Given this list of marker genes SLC40A1, RAB21, EPHA5, MIR326, COPS5, MIR766, CORO1A (coronin 1A), HCRT, MIR1-1, PTGDR, SYTL3, ERC2, JAK2, MIR199B, BEST1, KCND3, LTBP4, DLG1, RAB1A, SNAP47, ARF6, CPLX4, EXOC3L2, FOXL2, RAP1BL, CHRNA6, ABAT, AP1B1, WASHC1, ARHGAP44 (Rho GTPase activating protein 44), ADAM9, RAB10, F2, C1QTNF12, ITPR1, MYH9, VPS11, TBX3, RHBDF1, TVP23A, RBM4, CALM2, SLC8A3, DAB2, GCG, RPH3AL, STX11, MYO1G, DOC2B, SMCR8, ARFIP1, SCAMP1, IL11, RFX3, MECP2, PDZD11, SNAPIN, GRM7, FBXO45, ABCC8, LAT2, CYB5R4, HTR2A, SERP1, ADAM17, KDM5B, RIMS4, HRH3, MICAL3, ARL4D, CRHBP (NCBI Gene Id 1393), HYAL3, ECRG4, NOTCH1, TMEM132A, NLGN1, LAMP1, ADRA2B, TAC1, FFAR2, SVBP, GOLPH3L, RAB15, MPC2, ILDR1, SIRT4, KCNQ3, LRRC8A, SURF4, CREB3L1, TACR1, CD160, AGT, PHPT1, ACHE, CTAGE9, MYH10, ALOX5 (NCBI Gene Id 240), HPS6, KLRF2, PRKCG, SV2C, DNAJC1, PDIA4, TRARG1, DNAJC5, KCNMB4 (NCBI Gene Id 27345), NCKAP1L, PRKN, OSBPL2, ABCC4, SYN3, OR51E2, SNX19, PFKFB2, SLC12A2, SLC16A2, RAC1, MAFA, SCAMP5, BRSK1, KCNN4, TMEM167B, NRXN1, PPFIA2, CAPN10, RIMS1, CHMP3, SEC24A, RAB11FIP3, SEPTIN1, SAR1B, CLSTN3, PPFIA3 (NCBI Gene Id 8541), UNC13B, OSBP, VAMP8, MIR873, SUCNR1, ADORA1 (NCBI Gene Id 134), VPS18, NR0B2, TMEM163, STX1A, TLR4, MIR30C1 (microRNA 30c-1), CHD7, SELENOT, GDNF, HFE, FBXL20, PRSS12, INHBB, PPARD, IDH2, RAB11FIP2, SIRT3, ABCC2, SYBU, PLA2G6, RAB40AL, HAP1, ATP9A, RAB37, MIR21, BLOC1S3, STXBP5, PIK3CD, TSPAN9, AP1G1, ATP1A2, LRRK2, HIF1A, IL12B (NCBI Gene Id 7907), RALBP1, MIR19B1, WASH3P (WASP family homolog 3, pseudogene), PDX1, PFKL, DPH3, NNAT, MEF2C, ARFGEF2, STX19, HNF1B, GLUD1, CACNB4, EDN1, IRS1, DNM1L, RAPGEF4, TRH, SEPTIN4, BTK, FZD4, ERP29, C1QTNF1, NR1H2, SCG5, FAM3A, FGF10, COMP, GPER1, GNAI2, TMEM79, RAB26, P2RX1, SOX11, TCIRG1, ASIC1, KCNQ1, WASH6P, RAB25, RAF1, ABCA12, SEPTIN5, REST, C2CD2L, PLA2G4A, CHRNA3, GPLD1 (NCBI Gene Id 2822), SYP, C1QTNF3, FXYD6P3, KCNIP2, TNFRSF1A, ABCG2, MYOF, CAMK2G, ABCC5, FXYD3, PRICKLE1, ATP1A1, RIC1, MIA3, CASK, PRRT2, STEAP2, CTAGE15, JAGN1, MRGPRX2 (NCBI Gene Id 117194), AACS (acetoacetyl-CoA synthetase), PTGES, CAVIN1, FXYD7, MICU3, PDCD6IP, ABCA3, ATP1B3, NPFF, KCNK16, EFR3A, SYNGR2, GIPC1, CCL5, SNX4, GNPTAB, SELENOM, GHRL, SYT4, LRP5 (LDL receptor related protein 5), WNK4, SLC9A1, DYSF (dysferlin), SNF8, RAB8B, KCNJ11, ATP13A2, RAB11A (RAB11A, member RAS oncogene family), SLC35G1, WDR41, APBB3, SLC8B1, RAB12, RAB3D, BCR, KLF7, SYNGR3, SYT9, FKBP1B, EXOC6, TRPV6, LGALS9, PIP5K1C, FXYD2, SLC6A4, SMPD3, LEP, ANXA2, RAB33B, AP2B1, OXT, HAMP, ADORA2B, GRM4, PRKD1, KCNK2, F2RL2, FRMD4A, FOXO1, SEL1L, KCNA5, PPY, FGF7, GATA2, EXPH5, MIA2, M6PR, COMT, RAP1GDS1, UBE2Q1, UCN3, FOXA2, NOS2, LYN, SLC38A2, CHRNB4, FFAR4, MIR29B1, UNC13D, ADTRP, NRXN2, HLA-DRB1, KCNK9, SYT3, SYNGR1, ITGAM, SLC47A2, MIR93, SIRT6, RETN, SRCIN1, P3H1, RIMS2, SLC9B2, CTAGE8, ANO1, SYN2, STXBP1, TVP23C, CBLN1, MYO19, TANGO2, CD177, RAB3GAP1, SPP1, TREM2, APBB1, NAPA, SIDT2, SYT10, KCNE5, FMR1, STXBP6, SLC16A1, AVP, CLOCK, MIR19A, RPH3A, INHA, GPR68, APLN, NKX6-1, SYT15, RAC2, FUT10, SV2B, CD2AP, KLRC2, MIR185, CD200, PARD6A (NCBI Gene Id 50855), RHBDF2, ATP2A2 (NCBI Gene Id 488), MIR508, ITGB2, GRK2, BMP8A, SLC30A1, FXYD4, ABCB1, GJA5, SYT13 (NCBI Gene Id 57586), RAB40B, KRT20, SCT, SLC38A5, MIR133B, LILRB1, KCNJ8, MICAL1, RBP4, EXOC3L1, SMAD2, SYTL2, FCGR2B, YWHAE, HTR2C, RAB5A, SLC1A5, VPS4A, SCN11A, TGFB3, KCNB1, IL1B, SERGEF, HADH, FXYD5, SCRN1, CFTR, FXYD6, NSF, GRM2, CLTRN, FFAR1, BAIAP3, ARFGAP3, TRPM5, ABCG1, CDK5R2, GPR15LG, G6PC2, IL13 (interleukin 13), PCK2, FCER1G, RABEPK, SRI, FGF20, NPY2R (NCBI Gene Id 4887), PICK1, PCSK6, NDUFAF2, ORAI1, PLA2G1B, FAM3B, UCP2, GCK, P2RX4 (purinergic receptor P2X 4, NCBI Gene Id 5025), LIF, KCNK1, PPARG, SNAP25, GPR27, TFR2, GHRHR, WIPF3, BSG, SYK (spleen associated tyrosine kinase), STX3, AIMP1, B3GLCT, RIMS3, ATP12A, PRKCE, MYO18A, KCNT2, PINK1, SYT7, SYTL1, SNCG, GALR1, HNF1A, LLGL1, WNT7A, SLC30A2, UNC13C, SLC8A2, PORCN, LIN7C, LLGL2 (LLGL scribble cell polarity complex component 2), SPI1, EXOC3, BMP2, PTGDS (NCBI Gene Id 5730), RFX6, PFN2, MC4R, NKX3-1, CALM3, P2RY1, EXOC3L4, FGA, LMF1, KIF5B, F2RL1, SCIN (scinderin), DTNBP1, LGI3, CKLF, WLS, PKD1, TUNAR, CD33, SLC2A2, TACR2 (NCBI Gene Id 6865), WWP2, MIR146A, CCDC186, TPH1, MYOM1, SYTL4, KMO, PIANP, VAMP7, SLC27A1 (solute carrier family 27 member 1), GNAZ, COPG2, NR1H4, CACNA1B, TSPAN18, VSNL1, FGG, SYNJ1, NLRP5, ABCC1, PLEK, TMEM63B, CEACAM1, UCN, PSMD9, CBL, GSDMD, S100A13, GRXCR1, PCSK5, CADPS2, ENY2, AP1S1, PRKCB, TRPA1, NF1, PSEN1, SCRIB, SYT2, CPT1A, SLC47A1, ADORA3, BRSK2, RAB7A, AGTR1, CHRM3, GHSR, MIR129-1, CPLANE2, FUT11, ATP1B1, GAB2, TMF1, CD38, GNAS (GNAS complex locus), RAB11B, GJA1, SLC18A2, MIR186, ADIPOQ, CCN3, CCR1, SLC4A4 (NCBI Gene Id 8716), MERTK, SAA1, IL1RN, CHMP2A, NPVF, DRD2, BRAF (B-Raf proto-oncogene, serine/threonine kinase), RASGRP1, RAB11FIP1, FAM3D, EXOC5, SLC29A4, RALB, F2R, SYT12, NR1H3, PRKCA (NCBI Gene Id 5578), IL1RAPL1, SDC4, GNRHR, PRKG1, GPR151, RASL10B, ATP7B, KCNK18, RAB11FIP5, IL1A, LAT, CTAGE1, DYNLL1, CD84, CRH, GGCX, KCNE1, ABCA1, NEDD4, SNAP23, NAPB, FES, SLC25A22, KPNA4, CRY2, PDZK1, VPS35, ADRA2C, EXOC4, LTBP2, PPP3CA, CASR, CYP51A1, TRIM72, TNF, RAB3B, GIP, PCLO, BAD, SYT11, SLC44A4, GOLPH3 (golgi phosphoprotein 3), STX4, CHRNB2, UNC13A, CPLX1, S100A10, SLC22A5, APOE, NAGPA, TRPM4, RAB13, PTGS2, INHBA, GIPR (NCBI Gene Id 2696), PLA2G10, VGF, CANX, ATP4B, SNPH, TOR2A, ATP1A4, HTR1B, P2RX7, MCTP1, ANK1, RAB3C, CBARP, REN, CARTPT, ACSL4, HCK, ZP3, SLC22A2, ATP1B2, ADGRE2, SYCN (NCBI Gene Id 342898), EQTN (NCBI Gene Id 54586), INS, PIK3C2A, GNAO1, NGF, OSM, TGFB2, MIR199A1, PARK7, SYN1, TPCN2, NEDD4L, TMEM167A, CADPS, FCGR3A, CTAGE4, PTPRN, PPID, EXOC6B, CPE, RABGEF1, GPR119, MTTP, IGF1, SV2A, TGM2, SLC15A2, FGR, GRIK5, FOXF1, SYT6, OXCT1, PER2, STXBP5L, SLC30A8, SCG2, DVL1, TMED2, SYT8, VTI1B, CGA, CHMP6, DOC2A, VIP, CRHR1, SLC18A3, PDPK1 (NCBI Gene Id 5170, 3-phosphoinositide dependent protein kinase 1), TNFRSF1B, ADORA2A, TANGO6, AVPR1A, EXOC7, HGS, ARFGEF1, RAB40C, RALA, RAB2B, SNAP29, SLC4A8, PAK1 (p21 (RAC1) activated kinase 1), RSAD2, ADRA2A (adrenoceptor alpha 2A), VAMP2, HLA-F, SLC22A18, CCR2, CPLX2, GPRC6A, RAB44, STXBP2, RAB9A, ANG, SDCBP, FOXD1, KCNH2, PRAM1, EFNA5, MCU, CAMK2A, RAB40A, STAM, SLC30A4, GNA11, RAB27B, MIR9-1, SPHK2, TPRG1L, GRP, IL6, NTSR1, MIR451A, SMAD4, NECAB3 (NCBI Gene Id 63941), MIF, ITSN1 (intersectin 1), GLP1R, CHGA, APBA1, ATP2B3, PTPN11, ADCY5, ACVR2B, COPG1, GABBR1, ISL1, SERPINE2 (NCBI Gene Id 5270), CLASP2, ADAM8, RUFY4, ENSA, SNX6, OTOF, NPY, OPRM1, SYT17, SSTR5, SDHD (NCBI Gene Id 91899), C9orf72, CELA2A, SLC6A9 (NCBI Gene Id 6536), PPIA, PDE8B, NKG7, RAB3A, GATA1, TSPO, ZP4, RAPGEF3, AP1M2, SOX4, SLC8A1, EXOC8, KIT, RCN3, SLC38A3, IRS2, RAP1B, HMGCR, CRY1, TFAP2B, MIDN, MLXIPL, TLR2, MON1A, GAL, POMC, CALM1, BMP6, GIT1, CCKAR, SDF4, STEAP3, TNFAIP2, PFKM, ATP1A3, GDF9, SLC24A4, UQCC2, CDK5, KCNE2, CBLN4, SYTL5, NR4A3, PNKD, PPP3CB, TXLNA, MYB, OSCP1, NPPA, CYP19A1, RAB31, STXBP4, VPS13A, ANO6, FCER1A, KCNIP1, KCNE3, EDN3, SNCAIP, NMU, BMAL1 (NCBI Gene Id 406), DRD3, PAFAH1B1, GNAT1, CHRNA4, CSPG5, VEGFC, KCNA2, HTR1A, TYRO3, EXOC2, CCL8, TTN, IER3IP1 (NCBI Gene Id 55392), RHBDD3, AQP1, NPY5R, CPLX3, BLK, STX17, HNF4A, TCF7L2, MCTP2, PASK, PRKAR1A, IL4R, CLNK (cytokine dependent hematopoietic cell linker), FGF23, STXBP3, FFAR3, GATA3, CDK16, YKT6, CREB1 (NCBI Gene Id 1385), TRPV4, IFNG, FURIN, PAX8, RAP1A, USE1, HEPH (hephaestin), MILR1, BGLAP, SLC30A10, IL13RA2, SLC17A3, PIK3CG (NCBI Gene Id 5294), SACM1L, SYT5, KCNK5, SLC16A10, SLC32A1, TM7SF3, TNFRSF11A, RAB27A, NMB, TMEM38B, FGFR1, PTPN23, EXOC1, GHRH, NLGN2, ANXA3, PLA2G3, EIPR1, AXL (NCBI Gene Id 558), RGS9, TSPOAP1, FXYD1, KCNE4, ATP4A (NCBI Gene Id 495), CLASP1, HMGA2, FER1L5, VAMP3 (NCBI Gene Id 9341), NR1D1, IGHE, PLCB1, NTRK2, NKD2, CCL3, OLFM2, VPS4B, PIM3, TARDBP, TGFB1, PRKACA, ACVR1C, WASHC3, GPR158, STX1B, IL12A, PREPL, PTPRN2, PRF1, EDNRB, SDC1, FERRY3, FGB, NEO1, ATP2B1, CTAGE6, NADK, TMED10, RGCC, ANKRD1, ANXA1, SNCA, ILDR2, ADCY8, SYT1, APOLD1, ARL8B, NEUROD1, LIN7B, MIR34B, OPRK1, NIBAN2, DRD4, HCAR2, EPCIP, ABCB11, STX2, GNAI1, CD300A, PPT1 (palmitoyl-protein thioesterase 1), RAB8A, C1QTNF5, SREBF1, MIR495, LIN7A, MYRIP, BLOC1S6, ZBED6, ADCYAP1, MTNR1B (NCBI Gene Id 4544), CXCL12, TVP23B, TNFSF11, TRAPPC11, TSG101, MIR133A1 (microRNA 133a-1), here is a description of the gene set: The directed movement of some substance from a cell, into the extracellular region. This may occur via transport across the plasma membrane or via exocytosis. species: Homo sapiens Human Gene Set: GOBP_EXPORT_FROM_CELL